The following is a description of a gene set: B cells from human tonsil and blood were sorted using flow cytometry. The human samples were processed immediately ex-vivo using markers for known B cell subsets. Genes down-regulated in comparison of IgD- peripheral blood B cells versus pre-germinal center B cells. species: Homo sapiens from publication Longo NS, Lugar PL, Yavuz S, Zhang W, Krijger PH, Russ DE, Jima DD, Dave SS, Grammer AC, Lipsky PE (PMID 19023113) Human Gene Set: GSE12845_IGD_NEG_BLOOD_VS_PRE_GC_TONSIL_BCELL_DN, and this is the list of marker genes: MBP, FUCA1, BANF1, MYB, UBP1, KIF23, TNPO1, CHI3L2, PRR11, YBX1, POLA1, ELAVL1, PTGDS, MAP3K8, UBN1, CSE1L, ZC3H15, ZNF331, CROT, LBHD1, GEM, NAB2, LBR, SAT1, HIC2, RGL2, FOXD2 (forkhead box D2), PPP2R1A, TSR1, TUBB, VGLL4, TFDP1, RPL39L (ribosomal protein L39 like), HAUS2, SPINK2, SERPINE2, CD19, SIK1, SMARCA4, GPNMB, RACGAP1, CREG1, IRAG2, SIKE1, TAF5, PKD2, RGL1, HMGN2 (NCBI Gene Id 94860), HBEGF, FIRRM, RAD51C, MTCH2, CHD3, STK39, IPO9, RAD51AP1, POLE, TJP2, NR1H3, MSH6, RAN, RANBP1, RXRB, IL21R, MACROH2A1, SNRPD1, RRM1, XPNPEP1, LASP1, SLC25A3, LHFPL6, NAA38, TNFAIP3, GUSBP14, SPARC, TUBB2A, ACOT7, BST1, TTC23, CLTC, CGGBP1, ZNF160, PSMD14, HS2ST1, PLXNB2, RARS1, PFAS, LPP, DNAJC9, FABP5, HES1, SC5D, NKTR, SOX4, CCNB1, LPIN1, METAP2, HTR3A, CEP43, GNAS, NUP93, AICDA, NCBP1, NUDCD3, BRCA2, PIK3C2B, IPP, SNORA21, ARHGEF7, ADAMDEC1, CEP170, PPP6R1, CLEC4A, POLR1B, SNTB2, HAUS5, AURKB (aurora kinase B), RAD54B (RAD54 homolog B), MMD, HNRNPA1, PDCL, MTF2, SUGP2, CREM, SMPDL3A, DSN1 (DSN1 component of MIS12 kinetochore complex), HMHB1, SMC2, ATP8B1, NASP, RAD54L, MAB21L2, ACTB, INSIG1, CCL22 (NCBI Gene Id 6367), KTN1, ALDH2, TACC3, PDCD11, STIL (STIL centriolar assembly protein), MEST, MAFB, BUB1B, IGHV5-78, FN1, HMCES, TTF2, GRAMD1B, OLA1, ZFP36, NDC80, GJA1, CYP3A4, GINS1, ARHGAP26, CD72, SLIRP, AIMP2, PTPRE, EIF3B, SPDL1, YBX3, CSF1R (colony stimulating factor 1 receptor), PDGFD, AHCY, DDC, UBQLN4, PSPH (NCBI Gene Id 5723), ASB13, NUDT1, NEIL3, BCL7A, KANK1, NFATC3 (NCBI Gene Id 82543), MIA, MFAP1, LPXN, SORL1, VNN2, DZIP3, GRHPR, FBXO5, RASA2, TRAIP, RAP2A, TIMELESS, ANKRD11 (NCBI Gene Id 92821), IER3, MYO1E, HELLS, KDM4D, ERI2, SKIL, SLC35E1, CSTF3, GUSBP3, SIAH2, JUNB